The following is a description of a gene set: A protein modification process in which one or more covalently attached groups of a small protein, such as ubiquitin or a ubiquitin-like protein, are removed from a target protein. species: Mus musculus Mouse Gene Set: GOBP_PROTEIN_MODIFICATION_BY_SMALL_PROTEIN_REMOVAL, and this is the list of marker genes: Usp18, Usp25, Usp17la, Desi1, Usp24, Cops8, Usp45, Josd2, Senp2, Bap1, Vcpip1, Usp53, Usp17ld, Trim21, Uchl3, Tor1a (torsin family 1, member A (torsin A)), Cyld, Otub1, Tnfaip3, Otud4, Usp1, Usp49 (ubiquitin specific peptidase 49), Usp2, Tnip1, Usp5, Stambpl1, Zc3h12a, Usp48, Dnajb2, Semp2l1, Usp36, Abraxas2, Otulin, Otud6a, Usp44, Usp39, Mindy4, Shmt2, Usp32, Vcp (NCBI Gene Id 269523), Senp7, Otud6b, Usp40, Otud5, Usp47, Otud7b, Uchl4 (ubiquitin carboxyl-terminal esterase L4), Otub2, Psmd14, Usp3, Cops5, Senp5, Semp2l2b, Cops4, Brcc3dc, Usp33, Kdf1, Gps1, Cops2 (COP9 signalosome subunit 2), Uspl1, Usp30 (NCBI Gene Id 52294), Otud1, Usp16, Nop53, Josd1, Usp4, Itch, Usp7, Senp6, Usp21, Usp9y, Otulinl, Cops7a, Atxn3, Usp17lb, Usp42, Usp11, Senp1, Usp54, Yod1 (NCBI Gene Id 76190), Ubxn1, Mindy3, Usp8, Usp28, Usp37, Usp12, Usp34, Senp8, Senp3, Brcc3, Zranb1, Usp14, Cops6, Usp22, Spata2, Usp51, Uchl5, Otud3, Usp15, Usp20, Cops3, Usp29, Usp17lc (ubiquitin specific peptidase 17-like C), Stambp, Usp13, Usp50, Semp2l2a, Usp26 (NCBI Gene Id 83563), Otud7a, Usp17le, Usp38, Usp19, Usp46, Hint1, Usp43, Uchl1, Usp27x, Usp9x, Tank, Cops7b, Usp10, Park7